Given this list of marker genes Stard13 (NCBI Gene Id 243362), Mmrn1, Hdac5, Abl1, Klf4, Cib1 (calcium and integrin binding 1), Meox2, Fgf2, Map2k5, Map3k3, Nr2e1, Pdcd10, Fbxw7, Spred1, Gata2, Hdac7, Fgfbp1, Jcad, Hmox1, Akt3, Srpx2, Hdac9 (NCBI Gene Id 79221), Vegfa, Card10, Notch1 (notch 1), Nrp1, Rhoj, Rhoa, Tgfbr3, Dll4, Tbxa2r, Ptgs2, Pik3r2, Kdr, Anxa1, Itgb1bp1, Plk2, Foxc2, Thbs1, Pik3c2a, Mmrn2, here is a description of the gene set: Mouse Gene Set: GOBP_REGULATION_OF_CELL_MIGRATION_INVOLVED_IN_SPROUTING_ANGIOGENESIS species: Mus musculus Any process that modulates the frequency, rate or extent of cell migration involved in sprouting angiogenesis. Cell migration involved in sprouting angiogenesis is the orderly movement of endothelial cells into the extracellular matrix in order to form new blood vessels contributing to the process of sprouting angiogenesis.